Given this list of marker genes RFWD3, RAD51, RPA1, RAD51D, HELQ, XRCC2, RPA2, RPA3, RAD51B (RAD51 paralog B), RAD51C (RAD51 paralog C), RPA4, here is a description of the gene set: species: Homo sapiens Pathway Definition from KEGG: RFWD3 -| RPA,RAD51 == BCDX2+HELQ RAD51 -dsDNA destabilization. Pathway ID: N01539. Pathway type: Reference. Pathway class: nt06508 Interstrand crosslink repair. Human Gene Set: KEGG_MEDICUS_REFERENCE_RAD51_DSDNA_DESTABILIZATION